The following is a description of a gene set: species: Homo sapiens Human Gene Set: REACTOME_RET_SIGNALING RET signaling, and this is the list of marker genes: GAB1, GDNF, GAB2, IRS2, MAPK7, SHC1, GRB7, RAP1GAP, DOK6 (NCBI Gene Id 220164), SOS1, GFRA1, PTPN11, PLCG1, PIK3R2 (phosphoinositide-3-kinase regulatory subunit 2), DOK5, SRC, GRB10, GFRA4, PIK3R3, PIK3CD, PIK3CA, PIK3R1, DOK1, DOK4, PRKCA, GFRA2, PSPN, DOK2, GRB2, PRKACB, GFRA3, SHC3, PRKACA, PRKACG, PIK3CB, NRTN, ARTN (NCBI Gene Id 9048), PDLIM7, RET, FRS2